Given this list of marker genes OTUD4, IRAK3, MIR21, ST18, PLCB1, IRAK4, NFKBIA, RPS6KA5, MAP3K7, TOLLIP, PYDC1, IL1RAP, IKBKB, ZBP1, RELA, MYD88, TAX1BP1, SIGIRR, TNIP2, TRAF6, EGR1, IRAK1, MAPK3, MIR27A, VRK2, MIR146A, IRAK2, IL1RN, IL6, IL1RL2, IL1R1, IL1R2, RPS6KA4, ZNF675, IL1B, here is a description of the gene set: Human Gene Set: GOBP_INTERLEUKIN_1_MEDIATED_SIGNALING_PATHWAY The series of molecular signals initiated by interleukin-1 binding to its receptor on the surface of a target cell, and ending with the regulation of a downstream cellular process, e.g. transcription. studied in species Homo sapiens